The following is a description of a gene set: Human Gene Set: GOBP_CARBOHYDRATE_CATABOLIC_PROCESS species: Homo sapiens The chemical reactions and pathways resulting in the breakdown of carbohydrates, any of a group of organic compounds based of the general formula Cx(H2O)y., and this is the list of marker genes: PYGM, HMGB1, ATG2A, COL6A1, HKDC1, IER3, PKLR, GAA, MTCH2, ADCY10, FUT2, SLC2A6 (NCBI Gene Id 55587), SI, OGT, INSR, HK3, CBFA2T3, UCHL1, PGK2, GAPDH, FUT5, FOXK2 (NCBI Gene Id 84213), HK2, ENOSF1, NEU4, DHTKD1, SORD, PFKFB2, SCARB2, MLST8, HDAC4, CHIT1, APP, MAN2B1, ALDOC (NCBI Gene Id 230), PGAM4, PRXL2C, SRC, LCT, GLB1L2, TKTL1, PSEN1, CHIA, GPI, GLYCTK, WIPI1, ATG3, TRIM63, ZBTB7A, DDIT4, PRKAA1, PYGL, NEU2, NEU3, PFKP, MFSD8, ATG12, HEXB, TREH, OGDH, MANBA, ADPGK, GK (NCBI Gene Id 2710), GLB1L3 (galactosidase beta 1 like 3), MAN2C1, FLCN, NCOR1, CTBS, PHKG2, IFNG, LIPA, P2RX7, ALDOB (aldolase, fructose-bisphosphate B), BAD, EIF6, BCL2L13, HSD17B14, GM2A, IGF1, PFKL, ARNT, GALK1, MGAM, PYGB, RB1CC1, ACTN3, XYLB, HIF1A, TIGAR, PPP1R3D, MLXIPL, GALM, WDR45B, PGAM2, GIT1, FKRP, FBP1, DHDH, OGDHL, HK1, GCK, FOXK1, GALE, TPI1, TKFC, ENO2, FUT8, GSK3A, FUT7, ENO1, PPP1R3B (protein phosphatase 1 regulatory subunit 3B), UCP2, GK5, PGM2, EP300, MIR210, PFKM, STAT3, ARL2, TREX1, GLB1L, GAPDHS, NUDT5, PPARA, GABARAPL1, GK2, SLC4A4, ENO4, PRKAG1, PRKACA, FUT4, WIPI2, G6PC1, ZBTB20, PGM1, KAT2B, LRP5, SIRT6, MPI (mannose phosphate isomerase), PFKFB1, INS, GPD2, ATG2B, RBKS (ribokinase), GPD1 (NCBI Gene Id 2819), AMY2A, PHKA1, JMJD8, TP53, PRKAG3, AGL (NCBI Gene Id 178), GALT, MTOR, ENO3, FUT10, PFKFB3, HTR2A, NEU1, FUT6, STBD1, SLC4A1, PGAM1, WDR45, DERA, PGK1, PRKAA2, FUT9, GBA3, BPGM, FUT1, LDHA, MAN2B2 (mannosidase alpha class 2B member 2), PKM, PRKAG2, NUPR1, RPTOR, PPP2CA, PPP1CA, ALDOA, NAGA, GLB1